Given this list of marker genes Clstn3, Rgn, Gsto2, Gclc, Akr1b1 (NCBI Gene Id 11677), Slc23a2, Ugt1a6a, Pon1, Atp1a3, Pon3, Selenon, Gsto1, Gulo, Atp1a2, Pon2, Ero1a, Akr1a1, here is a description of the gene set: The chemical reactions and pathways involving lactone. Mouse Gene Set: GOBP_LACTONE_METABOLIC_PROCESS studied in species Mus musculus